The following is a description of a gene set: from publication Cui A, Huang T, Li S, Ma A, Pérez JL, Sander C, Keskin DB, Wu CJ, Fraenkel E, Hacohen N (PMID 38057668) Cytokines mediate cell-cell communication in the immune system and represent important therapeutic targets. A myriad of studies have highlighted their central role in immune function, yet we lack a global view of the cellular responses of each immune cell type to each cytokine. To address this gap, the authors created the Immune Dictionary, a compendium of single-cell transcriptomic profiles of more than 17 immune cell types in response to each of 86 cytokines (>1,400 cytokine-cell type combinations) in mouse lymph nodes in vivo. A cytokine-centric view of the dictionary revealed that most cytokines induce highly cell-type-specific responses. For example, the inflammatory cytokine interleukin-1β induces distinct gene programmes in almost every cell type. A cell-type-centric view of the dictionary identified more than 66 cytokine-driven cellular polarization states across immune cell types, including previously uncharacterized states such as an interleukin-18-induced polyfunctional natural killer cell state. Genes positively differentially expressed in cell type: pDC (plasmacytoid dendritic cell) upon treatment with cytokine: IL-18 in mouse lymph nodes in vivo. Mouse Gene Set: CUI_PDC_IL18_RESPONSE_UP species: Mus musculus, and this is the list of marker genes: Igtp, Mzb1, Iigp1, Gbp3, Irgm2, Irf8, H2-T23, Trafd1, Psma1, Cd72, Psmb9, Coq2, Ccdc162, Cox5a, Casp1, Ppa1, Csf2rb, Gbp4, Isg15, Ifi203, Dnajc7, Tapbpl, Cited2, Ptpn6, Cd52, Nampt, H2-K1, Ptpn1, Hivep3, Slfn5, Igkc (NCBI Gene Id 16071), Tap1, Ifi35 (NCBI Gene Id 70110), Parp9, Tap2, Lgals3bp, Gbp5, Zbp1, Cebpb, Klk1b27, Usp18, Atp2b4, Themis2, Cd82, Socs1, Rnf213, Brcc3, Actg1, Ifi207, Treml2, Dnajb11, Ly6a, Bcl11a, Irf7, H2-Q7, Mndal, Sgcb, Hck, Cpne2, Ifi44, Gbp7 (NCBI Gene Id 229900), Gbp8, Stat2, Abhd17b (abhydrolase domain containing 17B), Cnp, Lefty1, Irgm1, Pkib, H2-D1, Psmb10, Rnf115 (ring finger protein 115), Calhm6, Sting1, Slfn2, Clec2d, Serpina3g, Rasl11b, Atp6v1d, Pfn1, Csf2rb2, Samhd1, Trim12c, Runx1, Eif2ak2, Acadl, Jaml, Napsa, Stat1, Yae1d1, Parp14, Creb3, Tpm4, Psmb8, Nsmce1, Mx1, Irf1, Ifi47, H2-T22, Nmi, Ccdc124, Pmepa1, Rbm3, Kdr, Rap1a